The following is a description of a gene set: studied in species Homo sapiens Human Gene Set: MIR126_5P Genes predicted to be targets of miRBase v22 microRNA hsa-miR-126-5p in miRDB v6.0 with MirTarget v4 prediction scores > 80 (high confidence targets). from publication Chen Y, Wang X (PMID 31504780), and this is the list of marker genes: MAN1A1 (NCBI Gene Id 95122), FPGT, ERICH4, PMS1, MCTP1 (multiple C2 and transmembrane domain containing 1), FMC1-LUC7L2, TMEM182, SETBP1, PPFIA2, COL11A1, DHX35, PTPN4, MACC1, ZNF33B, DGKI, C5orf47, SRSF12, CCL28, IFI44, PRAMEF14, CFAP91, PIAS2, SCEL, ADCYAP1, UGT2B17, CDK19, XIRP2, PRPF8, MAP3K13, SPATA2, CHIC1, QRSL1, NLK, HOXB2, USP14, TBCA, RGR, CALCB, KCNV1, TNFAIP8L3, SLC2A11, MINDY2, NUP43, FAM78A, SENP7, CYP7B1, FAR2 (NCBI Gene Id 55711, fatty acyl-CoA reductase 2), CD2AP, C2CD4A, DCAF13, CUBN, MAP3K2, C8orf44-SGK3, POFUT1, HPSE, KBTBD6, MFAP4, EFR3A, GNE, EGFL6, FBXO6, GLYAT (glycine-N-acyltransferase), CACNB4, CLEC1A, HNMT, ZIC2, NAT1, ESRRG, CDC14B, JARID2, PTGS2, FRMPD4, NDUFAF3, SETD9, GABRB2, ADGRG2, RGS5 (NCBI Gene Id 8490), MDM4, ABCD3, MMRN1, C21orf91, JPT2, RSBN1, CHRNA5, TMX4, TNFSF4, GPBP1, SAMSN1, NHLRC2, ZKSCAN8, TET2, LTN1, DYRK2, PSMA1, PRAMEF2, ITGB6, ODR4 (odr-4 GPCR localization factor homolog), RWDD4, YIPF6, CAMK4, RAB30, PCBD2, ELAVL3, AHR, LRRTM3, FRYL, PHF23, SLC41A2, NWD1, L3MBTL4, BLTP3B, RAB31, LPP, SLITRK4, TBC1D15, RSPO3, INPP5D, AK2, FABP3, AP3B1, TUBGCP4, ANTXR2, CCDC149 (coiled-coil domain containing 149), KRAS, STEAP2, RBM41, KMT5A, L2HGDH, EIF4A2, ZNF10, GRM8, LETM2, EDA2R, MCHR2, PHKB, RTN4RL1, GRIN2A, KL, PLAG1, SLC49A4, KIF14, DBNDD2, ODAPH, FGG, CILK1, CCDC186, SLC16A7, RECK, ETV1, PNLIPRP3, GINS1, MED11, FUT9, COMMD2, AMFR, LRCH2, DCDC2, BRWD3, TMEM65, MDH1, RINL, SPRY4, CHURC1, HMCN1, CELF2, PTPN20, BDH2, SSBP3, FAXC, ZNF333 (NCBI Gene Id 84449), CA1, UBE2W, MMP16, USP12 (NCBI Gene Id 219333), PPP1R10, DNAJB4 (NCBI Gene Id 11080), PCDH7, INAFM2, SLC25A53, HERC3, MGAT3, PPIF, HECTD2, KLHL7 (kelch like family member 7), SRD5A3, TMEM33, NDUFS1 (NCBI Gene Id 55372), NACC2, RASA2, CAVIN2, TLCD4, SMCHD1, KLHL32, KCNN3, GMPPB, IDS, ACVR2B, CCP110, SYNPO2, HPN, FAM8A1, ZIC5, RABL3, ARID2, PREX2, MEF2D, WNT3, HOXA13, PRKCA, PRAMEF13, BLZF1, ACAN, MYEF2, EIF3J, ST8SIA3, TRIM8, AHCTF1, UBA3, BPNT2, HMGXB4, ELAVL4, COA8, ENOX2, P2RY12, FXN, VWA8, PLIN1, MR1 (NCBI Gene Id 3140), ELK4, FAM168A, ANTXR1, CNOT4, SPAST, ZBTB7C, NFIA, GASK1B, CNTN1, PDZD8, EPGN, KRT78, SHISA3, VWC2, HYDIN, CSF1, DMBX1, PPP1R1C, BICD2, ZBTB20, WASHC4, GPSM1, ZDHHC20, ADGRB3, ADAM9, ATP8B1, TRPS1, FNDC9, RGS4, HOXC8, ARL13B, IL7, SYT10, ARSK, MAPK10 (mitogen-activated protein kinase 10), ZDHHC15, KMT2A, LDLRAD2, ARL5A, MBNL3, GABRA4, MLPH, TRMT10A, SGPP1, TRMT9B, SHISAL1, B4GALT4, GOSR1, TGFBI, ZNF135, CPEB4, NXT2, KIRREL1, JPH1, RORA, ZNF687, CAMK2A, GET1-SH3BGR, C5orf34, RFX4, ARID1A, OCLN, GSK3B, PPP6R3, METTL17, DLG1, SOX6, PEX5L, CREB1, LRRC8D, SEMA6D, TCP10L2, SLIT2, MORC1, CHST7, FAM111A, SH3BGR, AIMP1, NFAT5, OSTF1, DENND1B, PLCB1, MSR1, SRFBP1, PF4, CD84, PKHD1, PRAMEF1, KIAA1549L, CSF2RA, GABRA5, TRPC5, RXFP1, GTF2F1, MMS22L, SLC7A14, TANK, TEP1, C6orf136, TSHZ3, ERGIC2, CDCA7, WDR64, PDLIM5, CTBS, CALHM1, NOVA1, PPARGC1A, SGK3, PATE1, PDE7B, CHMP5, CASK, FGF7, CALHM3, SLC19A2, IAH1, HSD11B1, NCAN (NCBI Gene Id 1463), WFDC13, DLL4, TAOK3, ADH4, UNC5D, GRIK1, TRDN, COLEC12, EPOR, VPS13A, CASP9, SP5, GUCY1A2 (guanylate cyclase 1 soluble subunit alpha 2), DPY19L2, GGT6, TECPR2, KPNA4, A2ML1, DICER1, DTD1, CCDC32, UBE3C, MBLAC2, VCPIP1, MTCL2, MEX3A, LONRF3, ZBTB41, ARL11, SULT6B1, NCOA7, PI15, PRXL2A, F9, EBF1, NIBAN1, HOXB6, LRRC3B (NCBI Gene Id 116135), ZNF695, PGAM4, NRG1, PTPN12, HSPB8, TMEM41B (NCBI Gene Id 440026), ZIC1, NFXL1, THRB, DAPP1, C22orf39, CYS1, IKZF2, REPS2, ZNF703, SNRPN, MOG, CHST11, LRRC74B, EREG, DLK1, PGC, NEGR1, WDHD1, BCAP29, EPS15, KCNB1, AMACR, PWWP2A (NCBI Gene Id 114825), UTRN, VPS13C, PEX13, SF3A1, ABCA5, ZNF33A, CCDC13, GRIK2, QPRT, TSC22D4, RP2, PAX2, DENND6A, THAP3, KAT2B, GRB2, MAT2B, PAN3, TTF2, MSRB3, LUC7L2, FSIP1, TRAF6, TRIP6, PROCR, SLC26A7, LARP4, TERB2, GLE1, USP10, ZBTB18, CCR1, HPS5, CTNNA3, S1PR3, PNRC1, EXD2 (exonuclease 3'-5' domain containing 2), LIN9, STX17, RFTN2, FGD2, TGFBR1, WASHC3, GABRA1, HOXB5, C17orf75, FAM199X, DKK1, UBN2, SLC6A15, TCHH